Given this list of marker genes Tgm3, Krtdap, Rps10, H2-D1, Sbsn, Adh7, Slpi, Ifi27l2a, Calr, Rack1, Defb4, Krt6b, Rpl38, Krt14, Ly6g6c, Krt16, Tpt1, Fdps (NCBI Gene Id 99573), Ces1d, Plac9, Pdzk1ip1 (PDZK1 interacting protein 1), Krtap3-3, Gstm1, Vsig8, Rps12, Rpl12, Krt84 (NCBI Gene Id 16680), Apoc1, Tmem254, Zfas1, Gstp1, Aldh3a1, Krt36, Sprr1b, Phlda1, Rps21, Eef1b2, Nqo1, Rplp2, B2m, Ptgr1, H2-K1, Rplp1, Gsta4, Ifitm3, here is a description of the gene set: Mouse Gene Set: TABULA_MURIS_SENIS_TONGUE_KERATINOCYTE_AGEING from publication Tabula Muris Consortium (PMID 32669714) species: Mus musculus